The following is a description of a gene set: Elevated urinary collagen degradation products studied in species Homo sapiens Human Gene Set: HP_ELEVATED_URINARY_COLLAGEN_DEGRADATION_PRODUCTS Increased level in the urine of a metabolite that results from collagen degradation, e.g., a fragment of a collagen produced by a collagenase or serine protease., and this is the list of marker genes: TNFRSF11B, PLOD1, NPR2, FN1, COL2A1